The following is a description of a gene set: species: Mus musculus from publication Zeilstra J, Joosten SP, Dokter M, Verwiel E, Spaargaren M, Pals ST (PMID 18483247) Mouse Gene Set: ZEILSTRA_CD44_TARGETS_DN Genes implicated in apoptosis that were down-regulated in duodenum of CD44 knockout mice. Mutation of the genes encoding the WNT signaling components adenomatous polyposis coli or beta-catenin plays a critical role in the initiation of colorectal cancer. These mutations cause constitutively active beta-catenin/TCF-mediated transcription, driving the transformation of intestinal crypts to colorectal cancer precursor lesions, called dysplastic aberrant crypt foci. CD44 is a prominent WNT signaling target in the intestine and is selectively expressed on the renewing epithelial cells lining the crypts. The expression of CD44 is dramatically increased in aberrant crypt foci in both humans and tumor-susceptible Apc(Min/+) mice, suggesting a role for CD44 in intestinal tumorigenesis. To study this role, we crossed C57BL/6J-Cd44(-/-) mice with C57BL/6J-Apc(Min/+) mice. Compared with C57BL/6J-Cd44(+/+)/Apc(Min/+) mice, C57BL/6J-Cd44(-/-)/Apc(Min/+) mice showed an almost 50% reduction in the number of intestinal adenomas. This reduction was primarily caused by a decrease in the formation of aberrant crypts, implying the involvement of CD44 in tumor initiation. The absence of CD44 in the normal (nonneoplastic) crypts of Cd44(-/-)/Apc(Min/+) mice did not alter the proliferative capacity and size of the intestinal stem cell and transit-amplifying compartments. However, compared with Cd44(+/+)/Apc(Min/+) mice, Cd44(-/-)/Apc(Min/+) showed an increase in the number of apoptotic epithelial cells at the base of the crypt which correlated with an increased expression of the proapoptotic genes Bok and Dr6. Our results show an important role for CD44 in intestinal tumorigenesis and suggest that CD44 does not affect proliferation but is involved in the control of the balance between survival and apoptosis in the intestinal crypt., and this is the list of marker genes: Serpinb9d, Cflar, Naip6, Parn, Bak1, Casp1, Tnfrsf12a, Tnfrsf17, Daxx